Given this list of marker genes S100A7A, TOX, PPP3CA (protein phosphatase 3 catalytic subunit alpha), DEPDC4, PKD2L2, WASHC5 (WASH complex subunit 5), KDM5B, CREB1, PPP4R3A, TMEM120B, ERCC1, ZC3H12D, GUCY1A2, IDE, TSPAN7, ACRV1, ARK2N, ZNF184, HDX, STEEP1, HOXB2 (NCBI Gene Id 3212), STX5, FRMD6, CNR1, GPR22, HS6ST3, IP6K2, NDE1, TNK2, ZBTB44, FAM111A, TMEM170A, ONECUT2, GPR107, TTC14, HIF3A, SMARCD1, PPM1B, NEXMIF, FAM81A (NCBI Gene Id 145773), LDHB, CDHR3, SRP72, NEXN, BCAT1, FXR1, CROT, SEMA5A, CLVS2, TMEM174, MINDY2, LPP, NEDD4, TFAP2A, RIMS3, EPHA7, ELOVL3, TMEM265, KPNA6, POLR3F, SCIN (scinderin), VAMP2, TAF11, MAGEA10, IRF2BPL, GTSF1, PRRX1, MCFD2, KRTAP5-10, ANKEF1, ERCC8, RBM46, FZD4, CHRNA3, FSD2, DENND4A, NRXN2, EIF2AK3, CREM, PLPPR4, PDE1C, PRDM10, ARL14EPL, IL36B, MRE11, AP3M1, TLR6, DUSP1, OSBPL8, ZKSCAN7, FZD10, IKZF4, XRRA1, DDX21, RLIG1, RORA, ZNF705A, PICALM, TCN1, COL1A2, ZSCAN23, VANGL1, KCNQ5, SMU1, MMP11, SLC10A7, SOS1, VPS53, OXSR1, RAB39B, TEAD1, PALM2AKAP2, DDT, CCNC (NCBI Gene Id 892), UBAP1, PAK3, PYGO2, LCP2, LMOD2 (NCBI Gene Id 442721), MYBL1, ANKRD34B, AAK1, SLC38A1, RAB3D, HSD3B2, MAT1A, CSMD3, BTN2A2, AGL, ZEB2, KMT2C, OXTR, EFR3A, FGF14, MMP28, EXOC6B, SESTD1, CNGA3, ADRB1, SAE1, PIAS3, FMO4, ST8SIA4, PFKFB3, CCDC39, SLC35B4, RSBN1 (NCBI Gene Id 54665), CD300LG, ITPRIP, SRRM1, USP25, MLH3, LARP1, CLEC3A, SLC39A11, SYPL2, MFGE8, FABP7, FOXP2, FOXRED2, CA3, MYF5, NCOA2, SUCLA2, CREBRF, DSC1, ADAMTSL1, KHDRBS2, STRN3, MAF, DSE, SLC36A1, JAZF1, ZDHHC21, ATP10B, PDLIM5, ERBB4, KICS2, PIANP, NBEA, DCLK1, RMI2, SPTLC2, KCNIP1, ZNF705D, SLC13A3, SCN7A, PDK3, MYCT1, VWC2, LRRC39 (leucine rich repeat containing 39), INTS6, DSCAML1, PHACTR2, DNAJB4, TMEM35A, MMP19, GFRA1, ZC3H11A, VSX2, NFAT5 (nuclear factor of activated T cells 5), NT5E, MTPN, UBXN7, SH3D19, FGF2, DAZ3, CLDN1, SOX9, STK24, ARF4, here is a description of the gene set: studied in species Homo sapiens from publication Chen Y, Wang X (PMID 31504780) Human Gene Set: MIR3185 Genes predicted to be targets of miRBase v22 microRNA hsa-miR-3185 in miRDB v6.0 with MirTarget v4 prediction scores > 80 (high confidence targets).